Given this list of marker genes Acta2, Arpc5, Upf1, Becn1, Rela, Igf1, Trp53, Ppp1r14b, Mtor, Mylk, Tjp1, Akt1, Orc1, Snai2, Anxa6, Rras2, Npm1, Ccl4, Pdgfb (NCBI Gene Id 18591), Hbb-bs, Il1b, Hbb-bh1, Cxcl5 (C-X-C motif chemokine ligand 5), Nasp, C7, Ccl5, Rac1, Atox1, Nucks1, Plau, Mmp3, Ccn2, Arpc3, Arpc2, Smad6, Rbbp4, Serbp1, Cxcl12, Sqstm1, Cxcl2, Mmp9, Plaur, Acta1, Orc2, Tnfsf13b, Cxcl1, Hmgb1, Blmh, Cpne1, Angpt1, Egfr, Mcm3, Cxcl15, Rhoa, Fbn1, Hyou1, Sod2, Mcm7, Rab10, Mki67, Il6, Zmpste24, Adh1, Mmp14, Psmc6, Mcm6, Atrx, Plch1, Snai1, Ccl3, Gap43, Ptgs2, Map1lc3a, Pik3c3, Smad7, Bcl2, Casp3, Mcm4, Pcna, Smad3, Mcm2 (NCBI Gene Id 17216), Jak2, Uggt1, Samhd1, Stat1, Cacybp, Map1lc3b, Smad2, Fn1, Cdc42, Gng12, Pak3, Col1a1, Prkacb, Pdgfa, C3, Hspa1b, Tgfb1, Stat3, Mcm5, Pura, here is a description of the gene set: Mouse Gene Set: WP_COMPREHENSIVE_IL17A_SIGNALING studied in species Mus musculus Comprehensive IL-17A signaling